Given this list of marker genes HLA-DQA1, LAPTM5, CD53, BIRC3, HLA-DMB, CD37, CD79B, NFKBID, LIMD2, REL, BANK1, CD83, LTB, HLA-DQB1, CORO1A, LINC00926 (NCBI Gene Id 283663), CXCR4, CD52, HLA-DRA, IGHM, HLA-DPB1, GPR183, TAGAP, MS4A1, EVI2B, IRF8, CD79A, POU2F2, VPREB3, MARCHF1, TNFRSF13C, CD74, LINC01781, HLA-DRB1, CD69, here is a description of the gene set: Human Gene Set: DURANTE_ADULT_OLFACTORY_NEUROEPITHELIUM_B_CELLS studied in species Homo sapiens from publication Durante MA, Kurtenbach S, Sargi ZB, Harbour JW, Choi R, Kurtenbach S, Goss GM, Matsunami H, Goldstein BJ (PMID 32066986)